The following is a description of a gene set: studied in species Mus musculus Long distance growth of a single sympathetic neuron projection involved in cellular development. A neuron projection is a prolongation or process extending from a nerve cell, e.g. an axon or dendrite. Mouse Gene Set: GOBP_SYMPATHETIC_NEURON_PROJECTION_EXTENSION, and this is the list of marker genes: Sema3f, Nrp2, S100b, Sema3a, Clstn3, Nrp1